The following is a description of a gene set: Any process that stops, prevents or reduces the frequency, rate or extent of microRNA processing. Human Gene Set: GOBP_NEGATIVE_REGULATION_OF_MIRNA_PROCESSING studied in species Homo sapiens, and this is the list of marker genes: BCDIN3D, ZMPSTE24, ZC3H10, HOXB-AS3, LIN28A, STAT3, TP53, LIN28B, IL6